The following is a description of a gene set: Skin tags Cutaneous skin tags also known as acrochorda or fibroepithelial polyps are small benign tumors that may either form secondarily over time primarily in areas where the skin forms creases, such as the neck, armpit or groin or may also be present at birth, in which case they usually occur in the periauricular region. Human Gene Set: HP_SKIN_TAGS studied in species Homo sapiens, and this is the list of marker genes: FGF3, KMT2D, COL2A1 (NCBI Gene Id 444981), FGFR2, ZFX, VPS13B, GPC4, EDNRA, FGFRL1, WLS, PTCH1, H4C3 (NCBI Gene Id 8364), FGFR3, POLR1D, CCDC22, EDN1, CHN1, KDM6A, ZNF668, STAG2, MSL3, SIX1, FLCN, KRAS (KRAS proto-oncogene, GTPase), BCOR (NCBI Gene Id 57686), POLR1B, CPLX1, SEMA3E, LETM1, PUF60, SNRPN, FGD1, NSMCE2, HNRNPU, NSD2, NAA10, SLC4A10, DACT1, EXT2, GNAI3, BRF1 (NCBI Gene Id 90137), B3GLCT, WASHC5, TXNL4A, SIX5, IRX5, TMEM260, GPR101, H4C9, LRP5, PIK3CA, MAFB, SALL1, PLCB4, ALX3, FGFR1, WBP11, PRDM10, GPC3, EFTUD2, RAP1B (NCBI Gene Id 5908), MED12, AIP, GLI2, KIF7, MED13L, SALL4 (NCBI Gene Id 57167), ALX1, FOXI3, FN1, PTEN, CTNND2, DPYSL5, EYA1, PRMT7, PIGS, SEMA5A, TCOF1, SF3B4, CTBP1, FLNB, ARID1B (AT-rich interaction domain 1B), RIPK4, SVBP, ANTXR1, SF3B2, H4C5, CHD7 (NCBI Gene Id 780907), VPS35L, AKT1, UBE3B, POLR1C, TASP1, ANKRD11 (ankyrin repeat domain containing 11), SMARCA2, ODC1